Given this list of marker genes MET, TMEM220, PRLR, CTR9 (CTR9 homolog, Paf1/RNA polymerase II complex component), RBM28, ARL8B, ALDH8A1, GDF6, ERMP1, PARPBP, SNX6, GTPBP8, MACROH2A1, MDGA2, LIMS1, KHDRBS3, MUC4, SLITRK1, OTUD7B, ARHGAP6, LAPTM4A, NSMF, PAIP2, LRIT1, TAF4B, SNRNP48, RCOR3, NDUFB5, KIAA1210, APAF1, CDH23, GPR137C, CLK4, KIAA1217, POP1, RGS18, PARP1, YEATS4, DEK, FAM149B1, HERPUD2, CCT6A, VLDLR, FPR3, FAT3, PRDM8, CMPK2, CPE, FBXO30, LPAR6, ZEB2, STYX, SDCBP, ARID1B, FLRT3, HOOK1, KDM3A, PGM2, INO80D, TSPYL5, GMFB, CDC42SE2, MBNL3, LRCH3, RPS6KA3, VGLL3, SNX1, PGM5, PDE1A, SPRED1, MRPL22, PHTF2, NSUN4, GLRA3 (glycine receptor alpha 3), RAI14, MIER3, BEND6, CDKN2C, IPMK, COL6A3, CHORDC1, DCAF7, PALM2AKAP2, GAPVD1, C5orf15, here is a description of the gene set: Human Gene Set: MIR4804_3P Genes predicted to be targets of miRBase v22 microRNA hsa-miR-4804-3p in miRDB v6.0 with MirTarget v4 prediction scores > 80 (high confidence targets). from publication Chen Y, Wang X (PMID 31504780) species: Homo sapiens